The following is a description of a gene set: Genes down-regulated in natural killer cell 1d vs 0d in adults after exposure to 2011-2012 trivalent inactivated vaccine (A/California/7/09 (H1N1), A/Perth /16/2009 (H3N2), B/Brisbane/60/2008), time point 1D. Comment: Down-regulated DE RNA transcripts (down >= 1.5x) shared between both TIV-vaccinated donors studied in species Homo sapiens from publication Hoek KL, Samir P, Howard LM, Niu X, Prasad N, Galassie A, Liu Q, Allos TM, Floyd KA, Guo Y, Shyr Y, Levy SE, Joyce S, Edwards KM, Link AJ (PMID 25706537) Human Gene Set: HOEK_NK_CELL_2011_2012_TIV_1D_VS_0DY_ADULT_1D_DN Systems biology is an approach to comprehensively study complex interactions within a biological system. Most published systems vaccinology studies have utilized whole blood or peripheral blood mononuclear cells (PBMC) to monitor the immune response after vaccination. Because human blood is comprised of multiple hematopoietic cell types, the potential for masking responses of under-represented cell populations is increased when analyzing whole blood or PBMC. To investigate the contribution of individual cell types to the immune response after vaccination, we established a rapid and efficient method to purify human T and B cells, natural killer (NK) cells, myeloid dendritic cells (mDC), monocytes, and neutrophils from fresh venous blood. Purified cells were fractionated and processed in a single day. RNA-Seq and quantitative shotgun proteomics were performed to determine expression profiles for each cell type prior to and after inactivated seasonal influenza vaccination. Our results show that transcriptomic and proteomic profiles generated from purified immune cells differ significantly from PBMC. Differential expression analysis for each immune cell type also shows unique transcriptomic and proteomic expression profiles as well as changing biological networks at early time points after vaccination. This cell type-specific information provides a more comprehensive approach to monitor vaccine responses., and this is the list of marker genes: JSRP1, AXIN2 (NCBI Gene Id 8313), TRIM46, TMEM150B, LILRA5, MIR4665, TTC24, GOLGA8R, ST14, HLA-DQA1, DIPK1B, TIGD5, ALKBH7, TTLL10, ENHO, LYL1, KLF3-AS1, AJM1, UPK2, IQSEC2, ASB13, TNNI2, MRPL23-AS1, CENPM, PLA2G7, SUSD3, LILRA4, PDXP, NCF4, ADAT3, LTK, COL18A1, SLC15A3, SLX1A, PDCD4-AS1, MAPK8IP1, TMEM238, KIF19, DNPH1, RTN4R, IGFBP7, SOX12, NICOL1, MYCL, PCSK4, FRS3, MIR3648-1, ZNF467, RN7SL2, PRSS36, AVPI1, FXYD7, FBXW9, EVA1B